Given this list of marker genes PSMD12, ERCC8, SCPEP1, COLEC12, RIN2, ACACA, DCSTAMP, PTGS1, CHP1, FEN1, SEPTIN2, MYOF, RDX, COMP, HLA-DMB, RENBP, H2AC6, MEA1, CCDC106 (coiled-coil domain containing 106), SLC1A4, DYNC1I2 (NCBI Gene Id 1781), NRGN, ZCCHC24, ERCC1 (ERCC excision repair 1, endonuclease non-catalytic subunit), MRC1, SCCPDH (saccharopine dehydrogenase (putative)), FPR3, HCK, ZNF124, CXCL8, CLIP4, ADAP2, ATP5MC1, VPS41, CLN8, IL13RA1, SC5D, PREP, PRDX6, ATP6V1H, ADCK2, C2CD2, NDUFA8, CYBB, SNX5, SMCO4, RXRA, ALDH1A1, ABHD6 (NCBI Gene Id 96026), PDLIM4 (PDZ and LIM domain 4), ACO1 (aconitase 1), LIMA1, CTNNAL1, TPP1, UGP2, IGSF6, MRAS, CAT, DDX31, ANPEP, FCER2 (Fc epsilon receptor II), LILRA2, ABCC3, SLC47A1, SMAD6, ALCAM, KCNQ1, CYP27B1, SHB, SLC16A5, APP, KYNU, FRAT2, FKBP1A, TACSTD2, CERS6, PPARG, CLMN, FN1, PTRH2, ALAS1, PRDX3, RIPK4, LRRK1, CD1E, CSF1, STXBP1, VAMP3, CD83 (CD83 molecule), PSAP, IL6R, TNS1, CCRL2, FCGR2C, TRIP6, TNS3, SLC15A3, CPEB1, MAN2B1, ALDH1A2, CLCN7, CPQ, CCNH, RAB14, PRDM13, TCF4, MCUR1, WNT5B, GABRB2, FZD5 (frizzled class receptor 5), SPR, CYC1, ANXA2P1, CD33, CYB5R3, GATB, ARMCX1, ABCB4 (NCBI Gene Id 5244), SIL1, DAPK1, PDSS1, LGALS3, KPTN, MITF, RAB32, EHD4, EIF4E2, MID1IP1 (MID1 interacting protein 1), BCAT1, BASP1, LPAR1, TSG101, RASGRP3, OAS1, ANXA11, NQO1, SDC2, ADIPOR1, CFD, TM6SF1, H1-0, CST3, SEMA6A, DNAJB4, IFNGR2, SPINT2, GPX1, ATF3, CTNS, DAP, LRP10, SEPHS2, TIMP2, POLR1G, PCK2, CCDC88A, NLRP3, APH1B, CDK5, CD36, TRIO, ARID5A, CLPB, NRP1, FES, KMO, ETFDH, SEL1L, NANS, RTN2 (reticulon 2), CYP4F8, FAM162A, TOR3A, FCHSD2, PDGFC, MEIS3P1, NDRG2, CDKN1A, AP1M2, AKR1A1, AIMP2, SERPINA1, RITA1, TYROBP (transmembrane immune signaling adaptor TYROBP), HBEGF, CTSC, PCTP, PEA15, THBD, MYF6, PRCP, SLC19A1, TBC1D8, PABPC4, TGFBI, FUCA1, MRC2, TXNRD1, PECAM1, here is a description of the gene set: from publication Jeffrey KL, Brummer T, Rolph MS, Liu SM, Callejas NA, Grumont RJ, Gillieron C, Mackay F, Grey S, Camps M, Rommel C, Gerondakis SD, Mackay CR (PMID 16474395) In the present study we used Affymetrix oligonucleotide microarrays to produce gene transcription profiles for the major leukocyte types in humans. This comprehensive dataset enabled us to not only establish which genes were expressed in each leukocyte type, but also which genes were expressed in each subset after activation. The used of a comprehensive dataset of gene profiles from all the major human leukocyte subsets enabled a novel and powerful means for identification of genes associated with single leukocyte subsets, or different immune paradigms. Human Gene Set: GSE3982_DC_VS_EFF_MEMORY_CD4_TCELL_UP Genes up-regulated in comparison of dendritic cells (DC) versus effector memory CD4 T cells. studied in species Homo sapiens